Given this list of marker genes PTK2B, BCAR3, FBXW7-AS1, CRKL, CDC42, BCAR1, EDN1, PLCB4, EDNRA, SIX1, GNA11, EDNRB, here is a description of the gene set: A G protein-coupled receptor signaling pathway initiated by endothelin binding to its receptor on the surface of a target cell, and ending with the regulation of a downstream cellular process, e.g. transcription. species: Homo sapiens Human Gene Set: GOBP_ENDOTHELIN_RECEPTOR_SIGNALING_PATHWAY